The following is a description of a gene set: Mouse Gene Set: MIR_1668 studied in species Mus musculus from publication Chen Y, Wang X (PMID 31504780) Genes predicted to be targets of miRBase v22 microRNA mmu_miR_1668 in miRDB v6.0 with MirTarget v4 prediction scores > 80 (high confidence targets)., and this is the list of marker genes: Ing3, Fndc10, Spdya, Cep170, Htr2a, A630001G21Rik, Stc1, Znfx1, Nup58, Map3k9, Rab24, Synj2bp, Lipe, Kdm3b, Yme1l1, Mex3c, Rgs17, Pcdh15, Nipa1, Esyt1, Nlrp6, Sgo1, Adipor2, Dhx15, 1600012H06Rik, Tnks (tankyrase, TRF1-interacting ankyrin-related ADP-ribose polymerase), Rfc1, Sppl2a, Kdm2b, Ago3, Plekho2, Ntsr1, Zbtb41, Entrep2, Lhx6, Gna13, Dennd6a, Pik3r1, Gatad2a (NCBI Gene Id 97459), Cubn, Cnot4, Neo1, Prickle1, Mex3b, Pitpnm3, Six4, Muc15, Scd1, Hyal6, Rhoa, Cep350, Ddi2, Carhsp1, Nrip3, Vdac3, Mbnl3 (muscleblind like splicing factor 3), Marchf8, Akap8, Fndc9, Bloc1s4, Smarca5, Csn1s1, Trim25, Ptbp2, Seh1l, Ppargc1a, Rab21, Gm57857, Krtap4-16, Osbpl8, Zfp850, Smgc, Kif3c, Lcor (NCBI Gene Id 73153), Nup50, Idh3a, Sacm1l, Tal1, Ncam1, Lman2, Slc25a36, Rcn2, Zbtb4, Ets2, Ist1, Prss35, Fzd4, Dcaf10, Sh3pxd2a, Gm5591, Cul4a, Eif4a2, Letmd1, Stox2, Ccdc88c, Rrbp1, Thap4, Asic1, Serpinb9e, Tomm7 (NCBI Gene Id 66169), Zdhhc12, Carmil1, Reep1, Igf2r, Riiad1, Ccn2, Wnt5a, Actrt2, Ifit1bl1, Ccna2, Ccdc71l, Wee2, Dusp14, Tead1, Ocm, Pdia5, 4930563E22Rik, Zkscan17 (NCBI Gene Id 268417), Cdc5l, Ppat